The following is a description of a gene set: Human Gene Set: GOBP_NUCLEAR_EXPORT The directed movement of substances out of the nucleus. studied in species Homo sapiens, and this is the list of marker genes: ANKLE1, GSK3B, THOC6, RPS15, ATXN1, ANP32B, MDM2, GAS6, ALYREF, PCID2, NXF1, CHP1, SETD2, SSB, EGR2, ZC3H11C, ENY2, CSE1L, NUP155, SMG1, NXF2, PRKACA, YTHDC1 (NCBI Gene Id 91746), PABPN1 (NCBI Gene Id 8106), DDX19A, RANBP3L, TGFB1, NEMF, WNK1, SMG5, AKAP8L, NRDE2, POM121L2 (POM121 transmembrane nucleoporin like 2), HNRNPA2B1, XPO7, NEAT1, SEM1, SMURF1, UPF2, YWHAE, THOC2, RBM10, CDKN1B, DDX19B, FRAT2, THOC1, SP100 (NCBI Gene Id 6672), NCBP2, PTPN14, NXT1, TPR, RANBP17, THOC7, RANBP3, TXN, SMG6, RBM8A, MALT1, BARD1, AGFG1, NUP107, UBE2I, SDAD1, CHTOP (chromatin target of PRMT1), RBM15B, XPO6, PKD1, CALR, NUP85, SFN, LTV1 (NCBI Gene Id 84946), DDX39B, MDN1, RAN, NUP42, LSG1, NOP9, NUP62, RBM33, HDAC3, UHMK1, RAE1, CASC3, DESI1, NPAP1, MAGOHB, PRP4K, NCBP3, NUP98, NUP160, PARK7, EIF4A3 (eukaryotic translation initiation factor 4A3), THOC3 (THO complex subunit 3), C12orf50, ZC3H11A, POM121C, NOL6, CTDSPL2, EMD, DDX39A, ADAR, STRADB, XPOT, NPM1, MAGOH, SARNP, EIF4E, XPO1, CAMK1, HNRNPA1, EIF6, HSPA9, IFI27, WASHC4, RAPGEF3, SIRT7, PTPN11, RBM22, NMD3, POM121B, UPF1, CDK5, POM121, DHX9, NUP153, RIOK2, NXF2B, PPM1A, MCM3AP, FRAT1, RANGAP1, ALKBH5, THOC5, NXF5, NCBP1, SMG7, SIRT6, POLDIP3, NXT2, SRSF3, CCHCR1, NUP88, LZTS2 (NCBI Gene Id 84445), NUP214, PRKD1, NXF3, IWS1, FMR1, PHAX, RANBP2, FYTTD1, XPO5, HHEX, ZC3H11B, DDX25, XPO4, GLE1, NSUN2, STRADA, BAG3, NUP133, AHCYL1, NUTF2, IL1B, FAM76B, NUP188, RITA1, NUP93, CDKN2A, KHDRBS1, CPSF6, EIF4ENIF1 (NCBI Gene Id 56478)